Given this list of marker genes Adam21, Hvcn1, Izumo1, Catsper4, Kcnu1, Adam25, Izumo3, Catsperg1, Catsper1, Catsperb, Izumo4, Cd9, Zp3, Hyal5, Acr, Adam30, Adam2, Izumo2, Zp1, Catsper3, Zp2, here is a description of the gene set: Reactome Pathway: Fertilization species: Mus musculus This event has been computationally inferred from an event that has been demonstrated in another species.<p>The inference is based on the homology mapping from PANTHER. Briefly, reactions for which all involved PhysicalEntities (in input, output and catalyst) have a mapped orthologue/paralogue (for complexes at least 75% of components must have a mapping) are inferred to the other species. part of: Reproduction electronically inferred by orthology from the curated human pathway